The following is a description of a gene set: Maintaining the structure and function of the blood-brain barrier, thus ensuring specific regulated transport of substances (e.g. macromolecules, small molecules, ions) into the brain, and out of the brain into the blood circulation. Human Gene Set: GOBP_MAINTENANCE_OF_BLOOD_BRAIN_BARRIER species: Homo sapiens, and this is the list of marker genes: CD2AP, ZEB2, OCLN, ESAM, TJP3, LAMA2, LAMC1, SLC1A1, ABCB1, MFSD2A, WNK3, SLC12A2, VEGFA, ACTG1, NAGLU, CLDN3, ABCC8, CLDN1 (claudin 1), TJP2, SH3GL2, GJB6, GJA1, ITGB1, TSPAN12, IL6, LSR, MBP, JAM2, CLDN12, F11R, JAM3, DMD, ANGPT1, CLDN5, VCL, PECAM1, TJP1, CDH5, ACTB